Given this list of marker genes Hspd1, Bysl, Rrp12, Supv3l1, Pes1, Noc4l, Pa2g4, Nop16 (NCBI Gene Id 28126), Ddx18, Plk1, Myc, Tfb2m, Rabepk, Grwd1, Wdr74, Tbrg4, Aimp2, Utp20, Nop2, Pprc1, Srm, Nop56, Slc19a1, Mphosph10, Npm1, Map3k6, Plk4, Prmt3, Hk2, Mcm5, Ndufaf4, Slc29a2, Wdr43, Imp4, Ung, Rrp9, Sord, Mybbp1a, Ppan, Gnl3, Dusp2, Mrto4, Farsa, Tmem97, Cbx3, Phb1, Cdk4, Pus1, Exosc5, Las1l, Nolc1, Dctpp1, Mcm4, Ipo4, Hspe1, Nip7, Tcof1, Rcl1 (RNA terminal phosphate cyclase-like 1), here is a description of the gene set: studied in species Mus musculus Mouse Gene Set: HALLMARK_MYC_TARGETS_V2 from publication Howe DG, Blake JA, Bradford YM, Bult CJ, Calvi BR, Engel SR, Kadin JA, Kaufman TC, Kishore R, Laulederkind SJF, Lewis SE, Moxon SAT, Richardson JE, Smith C (PMID 30224793) Mouse genes annotated to HALLMARK_MYC_TARGETS_V2 based on orthology mappings provided by the Alliance Genome Consortium